Given this list of marker genes SPI1, CX3CR1, TYROBP, ITGAM, STAP1, here is a description of the gene set: species: Homo sapiens The directed killing of a target cell by a microglial cell. Human Gene Set: GOBP_MICROGLIAL_CELL_MEDIATED_CYTOTOXICITY